The following is a description of a gene set: Genes predicted to be targets of miRBase v22 microRNA mmu_miR_485_5p in miRDB v6.0 with MirTarget v4 prediction scores > 80 (high confidence targets). species: Mus musculus Mouse Gene Set: MIR_485_5P from publication Chen Y, Wang X (PMID 31504780), and this is the list of marker genes: Pacs1, Zfp202, Rnf222, Smg1, Pak1, Tardbp, Nsun6, Bahd1, Pacs2 (phosphofurin acidic cluster sorting protein 2), Vat1, Plxna3, Rbm4b (NCBI Gene Id 66704), Crx, C1qtnf6, Actr3 (NCBI Gene Id 74117), Sucla2, Nmnat2, Vps26a, Nr2e1, Myo10, Pank3, Plec, Slc41a1, Slc36a1, Rab8b, Maf, Sox5, Slc29a3 (NCBI Gene Id 71279, solute carrier family 29 (nucleoside transporters), member 3), Sec24d, Ubxn4, Nucb1, Tdrp, Tvp23a, Colgalt2, Pcgf3, Rd3, Etnk1, Cops7b, Vac14, Phaf1, Mon2, Dag1, Mgst3, Pcnx1, St8sia2, Dpagt1, Grem2, Adipor2, Mllt10, Msi2, Smagp, Ppargc1a, Cldn12, Ccser2, Ube2i, Mxi1, Ugt2b5, Tnpo2, Gltpd2, Lman2, Ssr3, Mgat5b, Col1a2, Usp8, Sh3pxd2a, Plxna4, Gphn (gephyrin), Mtcl2, Ugt2b37, Glce, Upf2, Wdtc1, Acsbg2, Tubb5, Ppp3r1, Igsf23, Lipa, Nhsl3 (NCBI Gene Id 97130), St3gal1, Tcta, Sarm1 (NCBI Gene Id 97709), Adamtsl3, Sox10, Slc37a2, Cry2, Mllt1, Smurf2, Gpr155, Pif1, Lrp4, Ogt, Rps6ka2, Cfap97, Sec16a, Ctdnep1